Given this list of marker genes MIR133A1, MIR328, KCNE5, NOS1AP, KCNE1, GJA5, RNF207, KCNH6, CACNA2D1 (calcium voltage-gated channel auxiliary subunit alpha2delta 1), KCNA5, CASQ2, MIR1-1, FLNA (filamin A), AKAP9 (NCBI Gene Id 10582), ZMPSTE24, KCNQ1, ANK2, CAV3, CACNA1D, KCNE4, SNTA1, SCN5A, SCN1B, NOS1 (nitric oxide synthase 1), SCN4B, KCNH2, KCNE3, WDR1, NPPA, KCNE2, here is a description of the gene set: Any process that modulates the establishment or extent of a change in membrane potential in the polarizing direction towards the resting potential in a cardiomyocyte. Human Gene Set: GOBP_REGULATION_OF_CARDIAC_MUSCLE_CELL_MEMBRANE_REPOLARIZATION studied in species Homo sapiens